Given this list of marker genes Ret, Adipoq, Agtr2 (NCBI Gene Id 11609), Wt1, Pax2 (paired box 2), here is a description of the gene set: studied in species Mus musculus Any process that modulates the rate, frequency or extent of metanephros development. Metanephros development is the process whose specific outcome is the progression of the metanephros over time, from its formation to the mature structure. The metanephros is an endocrine and metabolic organ that filters the blood and excretes the end products of body metabolism in the form of urine. Mouse Gene Set: GOBP_REGULATION_OF_METANEPHROS_DEVELOPMENT